The following is a description of a gene set: species: Mus musculus Mouse Gene Set: GOBP_FORMATION_OF_TRANSLATION_PREINITIATION_COMPLEX The joining of the small ribosomal subunit, ternary complex, and mRNA., and this is the list of marker genes: Mcts2, Eif2s2, Denr, Eif2s3x, Rpl13a, Eif2d, Eif4b, Mcts1 (NCBI Gene Id 68995), Eif4h, Eif5, Eif2s3y, Dhx29